Given this list of marker genes ADAR, PPIA, PDE12, NR5A2, PPIE, IFIT1 (interferon induced protein with tetratricopeptide repeats 1), NOTCH1, TOP2A, TOP2B, PPID, TARBP2, RAD23A, CD28, LARP1, SRPK2, CCL5, VAPB, TRIM38, GBP7, PKN2, SRPK1 (NCBI Gene Id 6732), FKBP6, PABPC1, TMEM39A, DDX3X, STAU1, HACD3, ADARB1, CNOT7, PPIH, DDB1, here is a description of the gene set: Human Gene Set: GOBP_POSITIVE_REGULATION_OF_VIRAL_GENOME_REPLICATION species: Homo sapiens Any process that activates or increases the frequency, rate or extent of viral genome replication.